Given this list of marker genes Jak3, Il2rb, Stat5b, Stat5a, Shc1, Il2rg, Il2ra, Il2, Lck, Syk (spleen tyrosine kinase), here is a description of the gene set: electronically inferred by orthology from the curated human pathway studied in species Mus musculus This event has been computationally inferred from an event that has been demonstrated in another species.<p>The inference is based on the homology mapping from PANTHER. Briefly, reactions for which all involved PhysicalEntities (in input, output and catalyst) have a mapped orthologue/paralogue (for complexes at least 75% of components must have a mapping) are inferred to the other species. part of: Interleukin-2 family signaling Reactome Pathway: Interleukin-2 signaling